The following is a description of a gene set: studied in species Homo sapiens Human Gene Set: GOBP_AXONAL_TRANSPORT_OF_MITOCHONDRION The directed movement of mitochondria along microtubules in nerve cell axons., and this is the list of marker genes: NEFL, TRAK1, HIF1A, UCHL1, MAPT, AGTPBP1, ARMCX3, SYBU (NCBI Gene Id 55638), HDAC6, FEZ1, MGARP, OPA1, SPAST, HSBP1, ACTR10, AGBL4